The following is a description of a gene set: Mouse Gene Set: GOBP_AMP_BIOSYNTHETIC_PROCESS The chemical reactions and pathways resulting in the formation of AMP, adenosine monophosphate. studied in species Mus musculus, and this is the list of marker genes: Pfas, Gart (phosphoribosylglycinamide formyltransferase), Prps2, Adk, Adss2, Adss1, Nudt2, Paics, Aprt, Adsl (adenylosuccinate lyase), Ppat, Ada, Hprt1, Pnp, Atic